Given this list of marker genes PRDM1, BSPRY, ITGB7, MSMO1, CANX, HSP90B1, ISG20, CDT1, ANKZF1, HMMR, GLS, PDS5A, FKBP11, ST6GAL1, DUSP5, BMI1, MARS1, TRAM1, SUB1, UNG, UBE2J1, C11orf24, SIRT3, PIM2, SEC61A2 (SEC61 translocon subunit alpha 2), RAB30, GLDC, GNG7, FADS1, DNAJB9, APOBEC3B, UAP1, PRR7, MYB, FHL1, ELL2, ATRX, TNFRSF17, UCK2, PAICS, SSR1, SEPTIN11, HIVEP2, MNAT1, CAV1, PDIA4, PPP1R2, CASP3, E2F5, TCERG1, IRF4, DDHD2, SLAMF7, B3GNT2, CD38, TAF9B, NSD2, GTF2IRD1, TNFAIP3, GID4, SLC38A2, SETBP1, GFPT1, TXNDC5, AURKA, here is a description of the gene set: species: Homo sapiens from publication Shaffer AL, Emre NC, Lamy L, Ngo VN, Wright G, Xiao W, Powell J, Dave S, Yu X, Zhao H, Zeng Y, Chen B, Epstein J, Staudt LM (PMID 18568025) The transcription factor IRF4 (interferon regulatory factor 4) is required during an immune response for lymphocyte activation and the generation of immunoglobulin-secreting plasma cells. Multiple myeloma, a malignancy of plasma cells, has a complex molecular aetiology with several subgroups defined by gene expression profiling and recurrent chromosomal translocations. Moreover, the malignant clone can sustain multiple oncogenic lesions, accumulating genetic damage as the disease progresses. Current therapies for myeloma can extend survival but are not curative. Hence, new therapeutic strategies are needed that target molecular pathways shared by all subtypes of myeloma. Here we show, using a loss-of-function, RNA-interference-based genetic screen, that IRF4 inhibition is toxic to myeloma cell lines, regardless of transforming oncogenic mechanism. Gene expression profiling and genome-wide chromatin immunoprecipitation analysis uncovered an extensive network of IRF4 target genes and identified MYC as a direct target of IRF4 in activated B cells and myeloma. Unexpectedly, IRF4 was itself a direct target of MYC transactivation, generating an autoregulatory circuit in myeloma cells. Although IRF4 is not genetically altered in most myelomas, they are nonetheless addicted to an aberrant IRF4 regulatory network that fuses the gene expression programmes of normal plasma cells and activated B cells. Human Gene Set: SHAFFER_IRF4_TARGETS_IN_ACTIVATED_DENDRITIC_CELL IRF4 target genes up-regulated in plasmacytoid dendritic cells compared to monocytes.